The following is a description of a gene set: Human Gene Set: ERWIN_COHEN_BLOOD_LIVE_VACCINE_TC_83_AGE_23_48YO_VACCINATED_VS_CONTROL_14DY_UP from publication Erwin-Cohen RA, Porter AI, Pittman PR, Rossi CA, DaSilva L (PMID 27870591) Genes up-regulated in blood vaccinated vs control in adults (23-48) after exposure to Live attenuated vaccine TC-83, time point 14D studied in species Homo sapiens Venezuelan equine encephalitis virus (VEEV) is an important human and animal alphavirus pathogen transmitted by mosquitoes. The virus is endemic in Central and South America, but has also caused equine outbreaks in southwestern areas of the United States. In an effort to better understand the molecular mechanisms of the development of immunity to this important pathogen, we performed transcriptional analysis from whole, unfractionated human blood of patients who had been immunized with the live-attenuated vaccine strain of VEEV, TC-83. We compared changes in the transcriptome between naive individuals who were mock vaccinated with saline to responses of individuals who received TC-83. Significant transcriptional changes were noted at days 2, 7, and 14 following vaccination. The top canonical pathways revealed at early and intermediate time points (days 2 and 7) included the involvement of the classic interferon response, interferon-response factors, activation of pattern recognition receptors, and engagement of the inflammasome. By day 14, the top canonical pathways included oxidative phosphorylation, the protein ubiquitination pathway, natural killer cell signaling, and B-cell development. Biomarkers were identified that differentiate between vaccinees and control subjects, at early, intermediate, and late stages of the development of immunity as well as markers which were common to all 3 stages following vaccination but distinct from the sham-vaccinated control subjects. The study represents a novel examination of molecular processes that lead to the development of immunity against VEEV in humans and which may be of value as diagnostic targets, to enhance modern vaccine design, or molecular correlates of protection., and this is the list of marker genes: ABCE1, SGPP1, RPS27L, NUCB2, CUL5, CCT2, IGLV1-44, HSP90AA1, ZRANB2, SPIN1, BUB3, GZMH, BZW1, PSMD14, JMY, SRP72, EXOSC8, ZNF518A, SLC39A6, RPL24, EPSTI1, USP1, LMAN1, CAAP1, CLK1, IFI6, GLOD4, DBF4, SLIRP, TMEM87B, ZNHIT3, SLC25A46 (NCBI Gene Id 91137), COX7A2, TMEM161B, ZNF600, DIPK1A, PHF10 (PHD finger protein 10), PPA1, UBE2Q2, C4orf46, MTO1, STAMBPL1, OSTC, IGKV3-20, METAP2, CLNS1A, TRAT1, EEF1B2, ZNF107, ATP8A1, POLR2K, BIRC2, LTN1, TMEM135, TOMM7, PNPT1, ITGB1, RPS17, NIPSNAP3A, EIF4A2, CBX3, MTDH, KLF12, FABP5 (fatty acid binding protein 5), COG6, PSIP1, GLS, TMEM263, FUBP1, GZMA, TCF12, ATP11C, SMC3, FYN, RAP1B, TMED5, CD2AP, CDKN2AIP, RCN2, N4BP2L1, PPIL3, LY6E, CD3D, CHMP5, COPS2, PNISR, NEMF, TGFBR3, ARMT1, MGAT2, DNTTIP2, TCERG1, PXYLP1, CRTAM, EED, CNIH4, C5orf24, LUC7L3, MOB1B, RPL17, TMX1, B3GNT2, ITGAV, TMEM126A, FBXW7, OAS1, SLC39A8, RORA, RPS7, IGKV3D-11, EEA1, PHF14, IFT80, FGFR1OP2, ELL2, ZCCHC10, EMC2, C2orf69, GOLGA8A, CRBN, SLC35A3, NME1-NME2, IGHA1, PPWD1, SAMD9, ERLEC1 (NCBI Gene Id 27248), RBAK, BDP1, KLHL14, TRAM1 (translocation associated membrane protein 1), TASOR2, DDHD2, ARPP19, IFT25, KRR1, CCAR1, HERC5, DNAJC15, MOB4, PDHX, RECQL, N4BP2L2, TRA2B (transformer 2 beta homolog), YWHAQ, PEX3, SYNCRIP, CFAP97, MRPL47, RAN, PRELID3B, IGKV1D-33, GBP3, CLIP4, TMF1 (NCBI Gene Id 7110), RTCA, IGHM, CPSF6, GIMAP6, GOLGA4, AASDHPPT, MIB1, PGGT1B, IBTK, ZNHIT6, RNF6, IGLV2-23, FRA10AC1, IGHG2, SLC25A32, MRPL3, MDFIC, OMA1, TMEM181, DNAJB9, ARGLU1, SCOC, KLRK1, PPIG, VTA1, RPL34, LRRC40, GBP1, SDAD1, RPS6KB1, RRM1, KIF2A, ARHGEF3, DIS3, CYCS, TIFA, GSKIP, MFSD6, MICU2, PRPF39, NUP54, PCGF5, SEC31A, ZNF639, GIMAP2, RFX7, MYSM1, CSGALNACT2, IGLV2-18, KICS2, BORCS7, HNRNPA3, ZMYM6, PIGK, IFIT5, NFU1, ZNF22, RSL24D1, SUN1 (NCBI Gene Id 80226, Sad1 and UNC84 domain containing 1), NRAS, ZNF451, C11orf58, RCBTB1, AMIGO2, ZNF770, RACGAP1, ZNG1F, TPD52 (NCBI Gene Id 7163), CHORDC1, SMARCA5 (NCBI Gene Id 8467), PREPL, ACADM, SRSF11, SKIC3, PIGY, NOC3L, CETN3, IGKC, THAP5, GCH1, XPOT, POU2AF1, ZC3H15, HAT1, TAF9, PCMT1, RABGAP1L, RPL26, ICE1, ATP5PF, NR2C1, AGL, CD69, DOCK10, ZNF644 (zinc finger protein 644), U2SURP, USP53, METTL5, NDUFA5, ITGA4 (integrin subunit alpha 4), YTHDC2, PYROXD1, FKBP11, SLAMF7, PRPS2, HDDC2, URI1, JCHAIN, USP16, TMEM209, TMEM64, ESF1, KRCC1, PRNP, C2CD5, PALM2AKAP2, TFRC, ANK3, FAM98B, SEC11C, SEC24A, RNFT1, PTCH1, LEPROTL1, CEP120, TMEM106B, PHTF2, INTS13, CRY1, IKZF5, SLC30A1, RPL22L1, GRPEL2, ABCD3, SRP19, RBMX, ARMC1, IFIH1, UBA2, NSA2, ZDHHC20, SREK1, CLEC2B, TIMM17A, CPEB2 (NCBI Gene Id 285549), OAS3, CCDC91, EIF3E, ASNS, VBP1, CPOX, RIOX2, MGAT4A (NCBI Gene Id 11320), UBR1, RWDD1, SUCLA2, CEP20, ZZZ3, ERAP1, UFL1, HMGN3, EXOC5, SAMD3, RSAD2, HNRNPA2B1, API5, CASP8AP2, ASF1A, ANKRD36 (ankyrin repeat domain 36), SRSF10, GZMK, IGHG1, TBC1D4, KPNA5, COMMD8, PRDX4, USO1, ERAP2, IGKV4-1, DCK, PRP4K (NCBI Gene Id 8899), CHML, UQCRH, CREBL2 (cAMP responsive element binding protein like 2), CMPK1, BAG4, MALT1, AP5M1, RANBP2, MAF, MATR3, ZBTB11, RBM15, RPAP3, GLCCI1, RLIG1, CHD2, CD47, ATR, SACS, ARMCX3, TMX3, MS4A1, NUDT21, TMEM243, MTR, ABCB10, SLC38A1, GOLGA6L9, UPF3A (NCBI Gene Id 95832), FAM20B, PCNA, MTREX, ZFP62, PSMA2, SAMD9L, DAB1, USP47, SSB, SMIM15, ZNG1C, NRIP1, SUB1, POLR2M, SEC63, SARNP, PIK3C2A, PPIP5K2, ZBTB41, C21orf91, MTHFD2, RASGRP1, DENND1B, DUT, LYZ, PSMC6, HINT1, SENP6, IL6ST, TENT4B, SERP1, N4BP2, RRAS2, FDX1 (NCBI Gene Id 2230), ATAD1, EIF1AY, TIA1, FASTKD1, OTUD6B, GET4, UBXN4, HMGB2, FUBP3, BCLAF1 (BCL2 associated transcription factor 1), DERL1, HSPH1, DENR (density regulated re-initiation and release factor), TBL1XR1, NOP58, MBNL2, PNN, OASL, LRRC8C (NCBI Gene Id 84230), PSMC2, CEBPZ, DEK, MANEA, NUDCD2, MRPS31, LSM7 (LSM7 homolog, U6 small nuclear RNA and mRNA degradation associated), PRKCI, TPP2, CAND1 (cullin associated and neddylation dissociated 1), FIGNL1, SETDB2, ZWINT, CHMP2B, EIF4E (eukaryotic translation initiation factor 4E), ELK3, TNFAIP8, PCMTD1, UBE3A, CMC1, CCNC, THUMPD1, SEC23A, MRFAP1L1, EFR3A, RPL36A, SHPRH, COX16, CCNG1 (NCBI Gene Id 900), CLEC2D, BTN3A3, NAE1, NME1, MESD, SRP9, PPP4R2, G3BP1 (NCBI Gene Id 10146), CCDC117, CAMK4, CKS2, TAF1D, EIF1AX, CDK17, THEMIS, KLRF1, GORAB, IFI44L, HIBCH, CENPK, ATM, EDRF1, FBXO3, PPA2, PPP4R3B, CD52, TLK1, KLHL28, NAA16, AKAP7, ANKRD28, PLEKHA1, TRMT11, LANCL1, MYBL1, CCDC14, ATF1, PNRC2, HS3ST3B1, IER3IP1, SNRPG, CACYBP, PABIR2, COPS4, AQP3, BCL11B, SUCO, DCAF13 (DDB1 and CUL4 associated factor 13), ARAP2, TNFRSF17, NR1D2, PRPF40A, TRMT13, SMC4, BTAF1, TYMS, IGKV1-5, TDG, KTN1, KLRC1, SLC18B1, TWF1, IFI44, EIF2AK3, MTX3, SLC5A3, ANKRD13C, TENT2, LEF1, COX7B, IFI27, CUL4A, PM20D2, ERH, NAA15, PMS1, ZBTB8OS, ZNF83, DNAJC10, ALG13, DDX60, TMEM126B, PHC3, BIRC3, TOMM5, IGHA2, SAR1B, CMPK2, LSM5, UBA6, TASOR, MZB1, IGHV4-31, IGLJ3, IMPA1, IL7R, HSP90B1, DR1, SH2D1A, ZNF721, LDHB, CBLB, PCLAF, CLDND1, AGPAT5, RALGAPA1, CREBZF (CREB/ATF bZIP transcription factor), ISG15, OXR1, ETNK1, UBR3, DENND4C, SLC33A1, HNRNPU, ZMYM2, SLC44A1, NME2, ATF2, PSMA3, COX11 (NCBI Gene Id 1354), PDP1, FAM169A, TMEM168 (transmembrane protein 168), TFAM, VEZT, SLC39A10, TXNDC5, TRIM22 (NCBI Gene Id 10346), ANP32E, LRPPRC, ZNF207, HLTF, RRM2, SNHG5, BMI1, NIFK, ARL5A, MAN2A1, HSPA13, FAM3C, SNRPE, ATP5PO, SNRPD2, PCNP, FKBP3, DMXL1, XAF1, DDX18, SUCLG2, SLC35B3, ZBTB1, ZBTB21, RBIS, DPM1, SEC61G, MITD1, ZNF146, AIMP1, DDHD1, MEX3C, SBDS, KLRC3, HMGB1, HSPE1, VPS54, TTC14, SRSF1, UQCRQ, PTAR1, RNF138, ACTR6, GPBP1 (NCBI Gene Id 65056), CLK4, STK39 (serine/threonine kinase 39), CMTR2, SHLD2, TSNAX, ZNG1B, C12orf75, IFIT1, ITK, PSMA4 (proteasome 20S subunit alpha 4), RTP4, COX6C, CEP57, RPL35, ZNG1A, TXNDC15, PCMTD2 (NCBI Gene Id 55251), CSE1L, NSMCE4A, WWP1, RANBP6, TMEM123, GOLT1B (NCBI Gene Id 51026), SGTB, KLRC2, HAUS1, IGKV3D-15, C3orf38, RPS24, UQCRB, LSM14A, ARID4B, RBM25, PRKACB, DARS1, DDX3Y, ARFGEF2, NPM1, ICE2, SREK1IP1, OAS2, ADD3, UTP23, PRRC1, ZCCHC7, SRSF3, AEBP2, RAP2C, DBI, ZNF655, RPL23, HSPD1, PPIB, NDUFA6, MAP4K5, RBM34, UAP1, AK3, RABGGTB, RAB11A, ZBTB38, ARHGAP5, RAP2A, GCOM1, CD28, ANKRD36B, BLTP1, TM9SF3, STT3B